Given this list of marker genes TP53, HMGA2, UBN1, H1-1 (H1.1 linker histone, cluster member), HMGA1, HIRA, LMNB1, H1-0, CABIN1, CDKN1A (NCBI Gene Id 1026), H1-2, ASF1A, H1-4, EP400, H1-3, RB1, H1-5, here is a description of the gene set: Formation of Senescence-Associated Heterochromatin Foci (SAHF) species: Homo sapiens Human Gene Set: REACTOME_FORMATION_OF_SENESCENCE_ASSOCIATED_HETEROCHROMATIN_FOCI_SAHF